The following is a description of a gene set: Any process that stops, prevents or reduces the frequency, rate or extent of regulated secretory pathway. Mouse Gene Set: GOBP_NEGATIVE_REGULATION_OF_REGULATED_SECRETORY_PATHWAY species: Mus musculus, and this is the list of marker genes: Rap1a, Cd300a, Trim9, Il13ra2, Notch1, Syt4, Spi1, Rabgef1, Rest, Bcr (NCBI Gene Id 71258), Braf, Hmox1, Adra2a, Ceacam1, Foxf1, Ccr2, Rap1b, Cd84, Stxbp3, Lgals9 (lectin, galactose binding, soluble 9), Fmr1, Gnai2, Pou5f1, Abr, Cbarp, Nckap1l